The following is a description of a gene set: studied in species Mus musculus Mouse Gene Set: GOBP_POSITIVE_REGULATION_OF_TRANSCRIPTION_REGULATORY_REGION_DNA_BINDING Any process that activates or increases the frequency, rate or extent of transcription regulatory region DNA binding., and this is the list of marker genes: Trim6, Niban2, Gata3, Ifng, Pax6, H1f0, Twist1, Igf1, Lamtor5, Rb1, Foxc1, Traf6, Ddrgk1, Dazap2, Hand2, Pou4f2, Neurod1, Pou4f1, Park7